Given this list of marker genes Cdc20, Igfbp5, Spp1, Gm4870, Ccna2, H2ac6, Ube2s, Prim1, Tagln2, Pcna, Rangap1, Dnmt1 (DNA methyltransferase 1), Gm4739, Serpinh1, Stmn1, Set, Ccnb2, here is a description of the gene set: Mouse Gene Set: SIMBULAN_PARP1_TARGETS_DN species: Mus musculus Poly(ADP-ribose) polymerase (PARP) is implicated in the maintenance of genomic integrity, given that inhibition or depletion of this enzyme increases genomic instability in cells exposed to genotoxic agents. We previously showed that immortalized fibroblasts derived from PARP(-/-) mice exhibit an unstable tetraploid population, and partial chromosomal gains and losses in PARP(-/-) mice and immortalized fibroblasts are accompanied by changes in the expression of p53, Rb, and c-Jun, as well as other proteins. A tetraploid population has also now been detected in primary fibroblasts derived from PARP(-/-) mice. Oligonucleotide microarray analysis was applied to characterize more comprehensively the differences in gene expression between asynchronously dividing primary fibroblasts derived from PARP(-/-) mice and their wild-type littermates. Of the genes monitored, 91 differentially expressed genes were identified. The loss of PARP results in down-regulation of the expression of several genes involved in regulation of cell cycle progression or mitosis, DNA replication, or chromosomal processing or assembly. PARP deficiency also up-regulates genes that encode extracellular matrix or cytoskeletal proteins that are implicated in cancer initiation or progression or in normal or premature aging. These results provide insight into the mechanism by which PARP deficiency impairs mitotic function, thereby resulting in the genomic alterations and chromosomal abnormalities as well as in altered expression of genes that may contribute to genomic instability, cancer, and aging. Genes down-regulated in MEF cells (embryonic fibroblasts) from PARP1 knockout mice. from publication Simbulan-Rosenthal CM, Ly DH, Rosenthal DS, Konopka G, Luo R, Wang ZQ, Schultz PG, Smulson ME (PMID 11016956)